Given this list of marker genes SMARCB1, MDM2, CHEK2, CDKN2A, TP53, here is a description of the gene set: Choroid plexus carcinoma Intraventricular papillary neoplasm derived from choroid plexus epithelium. Plexus tumors are most common in the lateral and fourth ventricles; while 80% of lateral ventricle tumors present in children, fourth ventricle tumors are evenly distributed in all age groups. Clinically, choroid plexus tumors tend to cause hydrocephalus and increased intracranial pressure. Histologically, choroid plexus papillomas correspond to WHO grade I, choroid plexus carcinomas to WHO grade III. studied in species Homo sapiens Human Gene Set: HP_CHOROID_PLEXUS_CARCINOMA